The following is a description of a gene set: Human Gene Set: GSE41867_DAY6_VS_DAY15_LCMV_ARMSTRONG_EFFECTOR_CD8_TCELL_DN from publication Doering TA, Crawford A, Angelosanto JM, Paley MA, Ziegler CG, Wherry EJ (PMID 23159438) During acute viral infections, naïve CD8+ T cells differentiate into effector CD8+ T cells and, after viral control, into memory CD8+ T cells. Memory CD8+ T cells are highly functional, proliferate rapidly upon reinfection and persist long-term without antigen. In contrast, during chronic infections, CD8+ T cells become “exhausted” and have poor effector function, express multiple inhibitory receptors, possess low proliferative capacity, and cannot persist without antigen. To compare the development of functional memory T cells with poorly functional exhausted T cells, we generated longitudinal transcriptional profiles for each. species: Homo sapiens Genes down-regulated in CD8 T effectors at acute infection with LCMV-Armstrong: day 6 versus day 15., and this is the list of marker genes: DDX56 (NCBI Gene Id 54606), MARCHF8, MAP7D1, FMC1, SLC33A1, POU4F2, CCDC22, TMEM147, SART3, GPR183, SEL1L3, IDI1 (isopentenyl-diphosphate delta isomerase 1), SEPTIN1, MAP4 (NCBI Gene Id 4134), TSN, LINC00938, EEF1AKMT1, WRNIP1, TVP23B, NR1H2, KLK13, RAB5B, SLC25A1, SCAF4, PAGR1 (NCBI Gene Id 79447), MBD2, PLEK, BABAM1, PAQR8, ARMH3, AMPD1, ZBED3, CLDN12, CCDC92, RNASE6, WNK1 (WNK lysine deficient protein kinase 1), LCK, PNMA3, CAPNS2 (NCBI Gene Id 92942), MAP2K1, TRPT1, ZMYND8, PUM2, CCT4, WIPF2, MYL11, MFAP3, LINC01003, CUEDC2, UNC5CL, VPS50, VPS26C, AP5M1, TRAPPC10, STAG1 (STAG1 cohesin complex component), CTR9, RASL10B, ZNF791, PRKAB1, CCDC125, CYP51A1, GOPC, ATF7IP2, TMEM9B, HPCA, CARMN, MARCO, HRAS, PPP6R3, ZNF548, FBP2, AFF3, PINK1, SFXN1, ESS2, PPM1B, HSP90B1, SC5D, FSHB, SOX1, MED1, XIST, PRPF3, CDC37L1, BTBD10, TRIP6, AKR7A2 (NCBI Gene Id 94395), RSPH9, SLC2A1, BTN3A2, IQGAP2, MOK, TM2D3, TMEM212, AHNAK, KIAA1143, MFSD3, CACYBP, ZNF668, LARP1B, TWF1, KCTD20, NOB1, RNF181, MIEF1, TMEM68, RDH5, PSMD14, RIPK3, RAB27A, C11orf24, FBXO28, IWS1, LINC00294, MILIP, NAP1L4, NABP2, ENOSF1, MPV17, STX2, PALM (paralemmin), VPS37A, SCAF8, ZBTB7B, RTN3, CADM1, RAB8A, DGLUCY, UBE2I, GNG5, BACH2, PLCB2, ZCCHC7, PEPD, FAM118B (NCBI Gene Id 79607), CCL21, NUP210L, ENSG00000288891, PMS2P1 (NCBI Gene Id 5386), CXCR5, ENTR1, NDUFB5, XBP1 (NCBI Gene Id 7494), SGCD, MCF2, PPIG (peptidylprolyl isomerase G), ZGPAT, RPL36AL, ZFPM1, PLA2G2A, DNAJA2, NPEPPS, UBA7, TOPBP1, PCID2, NUDCD3, NXT1, NRF1, SLC45A3, LSM14A, AAK1, PARP2, RCE1, CDK4, METRNL, PAQR7, GNA15, PTTG1, DCTN6, UBA5, MAB21L1, CD69, PSMC3, ZRSR2P1, SLC15A4, CNPY3, MBD1, RAP2B, TNRC18, KRT80, VPS4B, CTDSPL2, OPA3, SCML2, PAFAH1B3, KHDC4, UTP3, ANKLE2, DEAF1, ZNF22, MRPS30, IDO2, PKNOX1, MT1HL1, FKBP4, KRT77